Given this list of marker genes CEP295, KLC3, MAPRE2, KIF1C, KATNB1, GAS2L2, MACF1, KIF14 (NCBI Gene Id 9928), CFAP157, SPC24, KIF3B, CENPF, CCDC88B, CDK5RAP2, FAM161A, FGF13, EML4, KIF5A, SPAG5, PRNP, CETN2, S100A8, MACO1, STRBP, KIF21B, FSD1, STARD9, CAMSAP1, MAPT, KIF5C (kinesin family member 5C), FMN1 (NCBI Gene Id 649014), GAS2L1, KIF1A, HOOK3, EML2 (NCBI Gene Id 24139), NEFH, APC, KIF15, TRAF3IP1, CEP57L1, RPS3, CAPN6, MDM1, KIF7, CAMSAP3, KRIT1 (NCBI Gene Id 9602), WHAMM, MAP4K4, SPAST, BCL2L11, KIF25, TRIM54, CCDC181, SPIRE2, DNM1, TUBGCP5, FES, PSRC1 (NCBI Gene Id 96740), TPGS1, CCSAP, GJB6, SSNA1, HDAC6, HAUS4, SPEF1, UXT, SPAG6, KATNBL1, CEP290, GABARAPL2, NEIL2, DST, RAB11A, MARK4, KIFC3, DNAI7 (dynein axonemal intermediate chain 7), IRAG2, KIFC2, KIF23, KIF13A, KIF4B, CAMSAP2, CCDC88C, DCDC1, KATNAL1, NDC80, DIAPH3, JMY, MTUS2, VPS41, FAM83D, SBDS, NUF2, ABRAXAS1, ZNF207, CETN1, KIF26A, SKA2, SPACA9, CKAP5, CLASP1, KIF6, CEP44, TERF1, DRG1, LRPPRC, S100A9, SPIRE1, TOGARAM1, MX1, TUBGCP4, MAP1S, MAST2, REEP2, KATNAL2 (NCBI Gene Id 83473), PLK1, SAXO2, KIF16B, NEFM, MAP9, GOLGA2, TUBGCP2, CLIP1, SPATA4, CRIPT, KIF2C, EML1, NIN, MAPRE3, DNM2, KIF4A, SNCA, KIF26B, REEP3, MID2, JAKMIP1, KIFC1, CFAP144, CCDC187, CLIP2, RMDN3, LUZP1, PEX14, KIF27, REEP1, KATNA1 (katanin catalytic subunit A1), MTCL1, KIF3C, CCDC88A, FBXW11, MAP1LC3B, STIM1, KIF12, CEP57, NUMA1, SUN2, TPPP, EML3, SVBP, ENKD1, KIF28P, CRYAB, CDK5, DCLK2, VASH2, PAFAH1B1 (NCBI Gene Id 5048), LRRK2, EML5, NUSAP1, TTBK2, WDR90, CLIP4, SKA1, CCDC66, PRC1, ARL3, HOOK1, ARHGEF2, KIF21A, DNM3, MTUS1, HDGFL3, NDEL1, KIF3A, MAP1LC3B2, JAKMIP3, BIRC5, MAP1LC3A, KIF5B, GAS2L3, MAP1A, MAP6D1, RGS14, CETN3, MAP4, HAUS8, KIF20A, KNSTRN, RACGAP1, RCC2, NDE1, SKA3, FNTA, CCSER2, CEP350, MAST1, RMDN2, KIF9, KIF22, TUBGCP6, KNL1, JAKMIP2, VAPA (VAMP associated protein A), MAP7D2, FHDC1, CLASP2, TBCB, SPAG8, KIF2B, KIF20B, MAP6, KIF2A, DNM1L, DYNC1I1, GTSE1, GLI1, FTCD, KIF18A, DCTN1, GAS2, TOGARAM2, MAP1B, PPP5C, KIF1B, HOOK2, APC2, TRPV4, KIF13B, KIF17, CCDC170, MID1, CLIP3, POLB, GAS8, RAE1, HAUS6, EML6, OPA1, KIF24, VAPB, EZR, MAP7D3, CCDC69, TUBGCP3, CHP1, SAXO1, MAP10, FMR1, NME8, RMDN1, OGG1, CEP135, CCDC61, DCX, MAP2, CGN, SGIP1, KIF18B, MAPRE1, KIF19, GAPDH, RP1, NAV3, KIF11, GABARAP, ABRAXAS2, REEP4, DLGAP5, CENPE, MX2, HAUS7, NDRG1, here is a description of the gene set: Human Gene Set: GOMF_MICROTUBULE_BINDING species: Homo sapiens Binding to a microtubule, a filament composed of tubulin monomers.